The following is a description of a gene set: An abnormality of somatosensory evoked potentials (SSEP), i.e., of the electrical signals of sensation going from the body to the brain in response to a defined stimulus. Recording electrodes are placed over the scalp, spine, and peripheral nerves proximal to the stimulation site. Clinical studies generally use electrical stimulation of peripheral nerves to elicit potentials. SSEP testing determines whether peripheral sensory nerves are able to transmit sensory information like pain, temperature, and touch to the brain. Abnormal SSEPs can result from dysfunction at the level of the peripheral nerve, plexus, spinal root, spinal cord, brain stem, thalamocortical projections, or primary somatosensory cortex. Abnormality of somatosensory evoked potentials species: Homo sapiens Human Gene Set: HP_ABNORMALITY_OF_SOMATOSENSORY_EVOKED_POTENTIALS, and this is the list of marker genes: SAMD12, YEATS2, CYP27A1, SEMA6B, TIMM8A, TBC1D24, MARCHF6, MORC2, PRPS1, SPG7, STARD7, EPM2A, GJC2, HYCC1, TTPA, PLP1, LMNB1 (lamin B1), ABCD1, ATXN1, NHLRC1, ALS2